The following is a description of a gene set: species: Homo sapiens Assembly and trafficking of telomerase. Pathway ID: N01476. Pathway type: Reference. Pathway class: nt06510 Telomere length regulation. Human Gene Set: KEGG_MEDICUS_REFERENCE_ASSEMBLY_AND_TRAFFICKING_OF_TELOMERASE Pathway Definition from KEGG: TERC+TERT+Pontin+Reptin == DKC1+NOP10+NHP2+GAR1+NAF1 -> TERC+TERT+Pontin+Reptin+Dyskerins == WRAP53+TriC, and this is the list of marker genes: NHP2, CCT7, CCT2, GAR1, CCT6B, RUVBL2, TERT, RUVBL1, CCT3, NOP10, TCP1, DKC1, CCT5, TERC, CCT6A, CCT4, WRAP53, CCT8, NAF1